Given this list of marker genes SLC11A1, KRT84, PKDCC, MAL, ANXA3, GUSB, ADH1C, PLA2G4A, IAPP (islet amyloid polypeptide), CLEC4F, WNT10B, TENT5C, ANKH, COL14A1, MYO5B, BOLA2, MXD1, TNFRSF9, KHDC1L, PLD1, SLC5A1, SEZ6, LECT2, SUN2, RTN4, MELTF, CRHR1, ANGPT2, HSD17B2, RLN1, CCND1, SLC22A1, MED10, ZP2, FOXA1, COPRS, GJB6, REEP1, FBP1, SPTLC2, PRPH, ELF5, FHDC1, ARFGAP3 (ADP ribosylation factor GTPase activating protein 3), ITIH4, TACSTD2, LY6H, SLC52A2, ST3GAL5, SLC1A2, HBE1, RESP18, ARHGEF28, MST1R, CXCL13, SOCS2, ANTXR2, PDZK1IP1, NDUFA13, RFK, IL18R1, HCK, CASP4, SPARCL1, NDRG4, PNLIPRP1, ATOX1, NFKBIB, TNFRSF17, PIGR, TEKT2, DTX2, APOD, MRPS21, TNFRSF4 (NCBI Gene Id 7293), DPP7, CES1, SPRR2A, PLG, CDKN2B, ATF6, CDR2, CALCB, SYTL4, CA8, CTSB, TFAP2B, SMOC1, CTSA (NCBI Gene Id 5476), CYP11A1, CTSH, KLRG1 (killer cell lectin like receptor G1), MRPL11, PER1, CRYAA, POU2F3, F2, MTNR1A, CFTR, C9orf72, ADCY8, SGK1, KRT10, PLK2, TMEM50B, CLCN1, CADPS, IGFBP6, C19orf48P, OCA2, SPDEF, S100A8, MADCAM1, PTX3, PTHLH, BLNK, LCT, OCM2, STAT5A (signal transducer and activator of transcription 5A), TMEM62, PRKAR1B, TSPAN6, ARMC10, GSTT1, B4GALNT2, CHMP5, SERPINB1, VMP1, EN1, NDUFB11, SUCLA2, SGCG, PRKCSH, ANKRD1, SYT8 (synaptotagmin 8), MMP12, LRP1, CYSTM1, CLN3, EEIG1, INSM1, MBD6, TMEM43, PRPF38B, SEMA4F, TNNI1, ADPRM, GSTO1, MT4, COL6A3, SLC51A, AKR1C4, PROM1, SERPINB2, EIF4A1, LTK, GDF10, FAAH, CMTM3, FEZF2, KRT13, ZNF787, CR2, NPY, KRT86, IL12A, BMX, GNB4, SPTBN2, MFSD1, APP, ALDOB, PTDSS1, TRO, CCL1, ABCC8, KRT1 (keratin 1), COL17A1, CSF2 (colony stimulating factor 2), LDLR, SLC38A4, RXRA, TSHB, NEFH, PDGFRB, FABP9, ALOX12B, SCG5, CD5L, FCER2, TRABD, LBP, TRAF1, ELF3, CNN1, NMB, SLC12A3, HERPUD1, FBXO15, PSME2, here is a description of the gene set: In this study, we have investigated the effect of BLIMP1α on gene expression, cell differentiation and pathogenesis in normal human GC B cells using a non-viral vector based system Genes up-regulated in germinal center B lymphocytes: control versus over-expressing PRDM1. Human Gene Set: GSE27670_CTRL_VS_BLIMP1_TRANSDUCED_GC_BCELL_UP from publication Vrzalikova K, Vockerodt M, Leonard S, Bell A, Wei W, Schrader A, Wright KL, Kube D, Rowe M, Woodman CB, Murray PG (PMID 21411757) species: Homo sapiens